The following is a description of a gene set: Genes having at least one occurrence of the motif CACCRATANNTATBG in the regions spanning 4 kb centered on their transcription starting sites. This matches the CUTL1 transcription factor binding site V$CDPCR3_01 (v7.4 TRANSFAC). species: Homo sapiens Human Gene Set: CDPCR3_01, and this is the list of marker genes: RIPK4, TFAP2D, CNTN6, SIX1, LYPD6, ETV3, HNF1A, CER1, SIX3, CSMD3, PIP5K1A, ZIC4, FGF10, PAK3, SLC44A4, NPAS1, MYT1, HES1, FGF7, RBPMS, AMMECR1L, ZNF516-DT, TSPAN6, L3MBTL2, ADGRL2, POU2F1 (POU class 2 homeobox 1), SLAIN1, BMP4, FAM24B, ZIC1, PARP16, PTGFRN, SPP2, KCNK18, FOXB1, KBTBD12, WIPI1, FOXG1, SP6, CDK2AP1, NFIA, HDAC4, SOWAHA, BHLHE41, IRAK1, DLX5, UPP2, CRH, POU3F4, LINC02908, PPARG, HOXA4, MICAL2, MARK1, DYNC1I2, ZNF710, NTN1